Given this list of marker genes TMEM161B, NBEAL1, ADCYAP1 (NCBI Gene Id 116), ZFP36, FAM181A, TBC1D12, GINS1, MACIR, ZNF254 (NCBI Gene Id 9534), NFYB (NCBI Gene Id 4801), TUBB, OR2L13, FMNL2, MME, BTBD8, PSMC6, SP8, ARFGEF1, RGS5, SPOPL (speckle type BTB/POZ protein like), FRK, BROX, RC3H1, TDG, ABCE1, CLTC, UBE2B, RBFOX1, CLOCK, ACP1, CD200, CTNND2, SCN2A, KRTAP4-5, STRN, ZCCHC10, ACER3, ZNF117, HAND2, MOB1B, NAT2, PREX2, ITGB8, RGS2, ZNF280D, ACOX1, PLCXD3, MTF2, AP4E1, C16orf87, ATP7A, UBE2I, IDI1, KLF2, BBS10, CNTN3, CCT6A, ZFX, RAB6D, NEGR1, ZNF41, ALDOB, FGF14, SIN3B, PTPN13, CADM2, DCUN1D5, ZNF714, BCOR, CPEB2, INTU, INPP1, SLC38A2, B2M, NOVA1, CFAP65, ERAP1, KERA, ARAP2, ZNF699, BTG3, MEI4, C18orf54, LARGE1, RCN2, SGIP1, SPRED1, WNT5A, CCN2, RAB6A, NEXMIF, PRMT3, CNTNAP3B, MBD5, THAP9 (NCBI Gene Id 79725), IRF6, OBI1, USP16, PBRM1, FGL2, PURA, CILK1, ZNF569, PTER, RGMB, TMED7, VDAC1, NGLY1, TNPO1, BCHE, PSMA8, CNTN4, CUL2, CDK1, TMBIM4, CBLN2, CDH9, RDM1, MTARC2, PI4K2B, HIRA, CTTNBP2, MTHFD2L, DSTYK, MLLT11, AZIN1, ATP6V1C2, ZNF107, CDK17, COMMD8, TSPAN19, DYNLT2B, ZNF746, COG6, CFL2, ID1 (NCBI Gene Id 96820), SLC44A5, MARCHF6, SLC2A13, MIER3, HYCC2, RAI14, GABRG1, RNF44, MAP10, DIP2B, GALNT1, TSHZ1, CCDC82, BAHCC1, UFL1, ATP2C1, DCAF8L1, CHIC1, KDM7A, RORA, TENT4A, AGL, KIAA0408, PALS1, DENND1B, SEPSECS, RBL1, FSD1L (NCBI Gene Id 83856), NCAM2, VPS50, PLAGL1, HNRNPA0, MFSD14B, CDC42BPB, ZNF99, IYD (NCBI Gene Id 389434), KCNMB2, PLAUR, KHDC4, RPP30, TMLHE, THSD7B, PCGF3, CCDC141, PLAG1, PRLR, CNTNAP3 (NCBI Gene Id 79937), SOAT1, FBXO28, GPATCH2, ANXA7, TLK1, IFIT2, ETF1 (eukaryotic translation termination factor 1), IPO7, SHQ1, ZNF236, PLPPR4, PAFAH1B1, OLA1, FAM91A1, RAB6B, PRKAA1, RAP1A, OMA1 (OMA1 zinc metallopeptidase), SDK2, ZFP30, ZNF681, NAB1, COMMD3-BMI1 (NCBI Gene Id 100532731), PDLIM5 (NCBI Gene Id 10611), ANKRD13C, MTCL3, TUBB2B, RPE, PRKG1, ZNF678, CNR1, PPP4R4, FAM111A, COL11A1, SNRK (NCBI Gene Id 87229), ZNF273, MIPOL1, DPY19L4, CLASP2, RAB1A, PEX5L, TCP1, LLGL1, CHML, PTPN12, MTMR6, RB1CC1, PIAS2, CMTM7, ATAD1 (NCBI Gene Id 84896), NETO1 (neuropilin and tolloid like 1), here is a description of the gene set: from publication Chen Y, Wang X (PMID 31504780) studied in species Homo sapiens Human Gene Set: MIR195_3P Genes predicted to be targets of miRBase v22 microRNA hsa-miR-195-3p in miRDB v6.0 with MirTarget v4 prediction scores > 80 (high confidence targets).